The following is a description of a gene set: Human Gene Set: GOBP_SEMICIRCULAR_CANAL_DEVELOPMENT studied in species Homo sapiens The progression of the semicircular canal from its initial formation to the mature structure., and this is the list of marker genes: NR4A3, EYA1, HOXA1, GATA2, TBX3, TBX1 (NCBI Gene Id 7413), GLI3, FGF10, SPARC, CHD7, ZEB1